Given this list of marker genes Resf1, Spocd1, Dnmt3l, Piwil2, Mphosph8 (M-phase phosphoprotein 8), Mov10l1, Tex15, Morc1, Gm38999, Tdrd9, Setdb1, Fkbp6, Piwil4, Mael, Dnmt3a (NCBI Gene Id 97846), Tdrd1, Tdrd5, Ddx4, Tasor, Tdrd12 (NCBI Gene Id 73691), Piwil1, Smyd5, Spin1, Morc2a, Dnmt3b, here is a description of the gene set: A transposable element silencing mechanism involving heterochromatin assembly. Heterochromatin is a chromatin conformation that is refractory to transcription. Mouse Gene Set: GOBP_TRANSPOSABLE_ELEMENT_SILENCING_BY_HETEROCHROMATIN_FORMATION species: Mus musculus